Given this list of marker genes Klc1 (kinesin light chain 1), Mecp2, Hspb1, Ap3b2, Arl8a, Actr10, Hdac6, Kifc2, Stau1, Pafah1b1, Snapin, Bloc1s6, Kif21a, Wasf1, Spast, Dync1h1, Kif5c, Bloc1s3, Sybu, Ap3m1 (adaptor-related protein complex 3, mu 1 subunit), Atg16l1, Pura, Sod1, Hif1a, Tmem230, Spg7, Kif21b, Hnrnpu, Borcs5, Map1a, Kif17 (kinesin family member 17), Trak1, Cnih2, Kif1a, Kif2a, Map2, Klc3, Ap3m2, Ank3 (ankyrin 3, epithelial), Myo5a (myosin VA), Bloc1s1 (NCBI Gene Id 14533), Fez1 (NCBI Gene Id 235180), Fbxw11, Hsbp1, Agbl4, Caly, Flot2, Nefm, Atg5, Terf2, Kif1c, Kif5a, Ndel1, Spg11, Ap3d1, Rab27b, App, Rab21, Hap1, Ap3s2, Bsn, Dst, Armcx3, Kif5b, Bloc1s2, Kif3b, Bloc1s4, Ap3b1, Klc2, Nefl, Map6, Trak2, Tmem108, Kifap3, Kif1b, Dlg2, Arl8b, Rab17, Trim46, Dtnbp1, Neto1, Ap3s1, Mgarp, Mapt, Madd, Sfpq, Stau2, Rabgef1, Mapk8ip3, Agtpbp1, Kif3a, Uchl1, Htt, Bloc1s5, Hspa8, here is a description of the gene set: Mouse Gene Set: GOBP_AXO_DENDRITIC_TRANSPORT studied in species Mus musculus The directed movement of organelles or molecules along microtubules in neuron projections.